The following is a description of a gene set: Human Gene Set: FINETTI_BREAST_CANCER_KINOME_GREEN Breast cancer is a heterogeneous disease made of various molecular subtypes with different prognosis. However, evolution remains difficult to predict within some subtypes, such as luminal A, and treatment is not as adapted as it should be. Refinement of prognostic classification and identification of new therapeutic targets are needed. Using oligonucleotide microarrays, we profiled 227 breast cancers. We focused our analysis on two major breast cancer subtypes with opposite prognosis, luminal A (n = 80) and basal (n = 58), and on genes encoding protein kinases. Whole-kinome expression separated luminal A and basal tumors. The expression (measured by a kinase score) of genes encoding serine/threonine kinases involved in mitosis distinguished two subgroups of luminal A tumors: Aa, of good prognosis and Ab, of poor prognosis. This classification and its prognostic effect were validated in 276 luminal A cases from three independent series profiled across different microarray platforms. The classification outperformed the current prognostic factors in univariate and multivariate analyses in both training and validation sets. The luminal Ab subgroup, characterized by high mitotic activity compared with luminal Aa tumors, displayed clinical characteristics and a kinase score intermediate between the luminal Aa subgroup and the luminal B subtype, suggesting a continuum in luminal tumors. Some of the mitotic kinases of the signature represent therapeutic targets under investigation. The identification of luminal A cases of poor prognosis should help select appropriate treatment, whereas the identification of a relevant kinase set provides potential targets. from publication Finetti P, Cervera N, Charafe-Jauffret E, Chabannon C, Charpin C, Chaffanet M, Jacquemier J, Viens P, Birnbaum D, Bertucci F (PMID 18245477) species: Homo sapiens Genes in the green cluster of protein kinases distinguishing between luminal A and basal breast cancer subtypes., and this is the list of marker genes: ZAP70, FGR, STK10, MLKL, JAK3, PIM2, LCK, MAP4K1, STK17B, BTK, PRKCB, HCK, SYK, ITK, PRKCQ, LYN